The following is a description of a gene set: Mouse Gene Set: GOBP_REGULATION_OF_RECEPTOR_BINDING Any process that modulates the frequency, rate or extent of a protein or other molecule binding to a receptor. studied in species Mus musculus, and this is the list of marker genes: Phlda2, Ldoc1, Adipoq, Bdnf, Atp2a3, Hfe, Crtac1, Mmp9, Plcl2, Lox, Ptprf, Adam15, Pcsk9, Nog, Atp2a2, Rgma, Anxa2, Il10, Grem2, Plcl1, B2m